The following is a description of a gene set: Mouse Gene Set: GOBP_ESTABLISHMENT_OF_LEFT_RIGHT_ASYMMETRY The initial formation of the type asymmetry in an organism's body plan or part of an organism with respect to the left and right halves. species: Mus musculus, and this is the list of marker genes: Dnaaf2, Cfap45 (cilia and flagella associated protein 45), Ccdc39 (NCBI Gene Id 99728), Cfap52, Cirop, Pierce1, Enkur